Given this list of marker genes IGHE, VAMP8, VAMP7, TRAF3IP2, CCL3, VAMP2, CCR2, F2RL1, STX4, FCER1A, here is a description of the gene set: species: Homo sapiens Any process involved in the carrying out of an immune response by an eosinophil. Human Gene Set: GOBP_EOSINOPHIL_MEDIATED_IMMUNITY